The following is a description of a gene set: The aggregation, arrangement and bonding together of a set of components to form an U2-type prespliceosome. Mouse Gene Set: GOBP_U2_TYPE_PRESPLICEOSOME_ASSEMBLY studied in species Mus musculus, and this is the list of marker genes: Sf3a3, Htatsf1, Ddx42, Ddx46, Sf3a2, Sf3a1